The following is a description of a gene set: species: Homo sapiens Human Gene Set: GOBP_NUCLEAR_MIGRATION_ALONG_MICROTUBULE The directed movement of the nucleus along microtubules within the cell, mediated by motor proteins., and this is the list of marker genes: SUN1, SYNE2, TRIM58, SUN2, TMEM201